Given this list of marker genes GAL, FOXO4, TGFB1, MYRF, FOXO3 (NCBI Gene Id 2309), SOD2, PENK, MDM2, GPI, NR0B1, LRP11, CRH, PITX3, HDAC6, BRD1 (NCBI Gene Id 29975), REN, GOT1, UGT8, CERS2, UCN3, PPP1R9B, TFF1, GLTP, FOS, CYP1A1, here is a description of the gene set: Human Gene Set: GOBP_RESPONSE_TO_IMMOBILIZATION_STRESS studied in species Homo sapiens Any process that results in a change in state or activity of a cell or an organism (in terms of movement, secretion, enzyme production, gene expression, etc.) as a result of being rendered immobile.